Given this list of marker genes PTH1R, ISCU, EPS15, MMD, SSTR3, FABP6, LACTB, BDKRB2, EEF1AKMT1, UPB1, SUCO, NID1, CD72, SPTLC1, BHLHE23, ID4, TBL1X, CXCL10, FAM89B, TCEAL9, NUDT9, HVCN1, IGF2R, CUX2, RILPL1, TNFAIP8L1, CSRP1, STX1A, CPA3, TSHR, CD274, RTBDN, EPAS1, SARDH, CLDN23 (claudin 23), OSMR, COL8A1, NEK7, TGDS, MCCC2, PRDM5, UNC50, AKNA, MAPRE2, ST8SIA1, EMP3, CD84, ADAM10, WNT1, HOXB7, CLCF1, LTF, FBXL3, APOB, COX6C, TNFSF11 (NCBI Gene Id 8600), CKB, TPGS2, PLEKHA2, YEATS4, SRFBP1, FASLG, MAL, UCN2, SELENOV, PIP4K2A, TNFRSF1B, SYNJ2, SRPX2, TTC3, FABP9, LAD1, B3GNT2, DNAJC15 (DnaJ heat shock protein family (Hsp40) member C15), ADCY4, NRK, KRT7, SIRT2, MSRA, RASGRP4 (NCBI Gene Id 115727), SLC17A2, TRAPPC1, GLIPR1 (GLI pathogenesis related 1), SCNN1A, G6PC1, FAM184B, CCL20, ITM2A, IKBKB, KRTAP20-2, DNAJA3, GRIA4, CTSV, EFNA5, ECI1, RAB11B, HLA-G, SPINT2 (serine peptidase inhibitor, Kunitz type 2), HMGN5, PPP3CA, RBX1, BEX3, RRAS2, ACAA2, SESN1, GPR153, MBP, CD96, CCDC86, DUSP6, PUM3, TMEM258, EDARADD, PDC, ADAM19, NKX2-8, TRIB3, CD3G, CADM1 (cell adhesion molecule 1), TUBB2A, SH3BP5, VPS13C, TMCO6, CNTN6, LONP2, DENR, TNNT2, DPY30, OMD, CA2, TIMP2, GTF2IRD1, MRPS33, RTL6, PDLIM4, ARR3, GOLM1, TTC7B, ANP32A, HNRNPLL, PAG1, FYCO1, EPB41L2, CCDC102A, EMC9, RHOV, XCL1, CNIH4, EVI2A, MPC2, REEP3, SERPINC1, CARMIL1, MAPRE1, LMOD2, TUFT1, AREG, CAST, NKD2, PHLDA1, MBOAT7, STAG2, ANTXR1, FCGR2A, PDCL3, TBL1XR1, TMEM38B, SH2D1A, C8orf76, AKR1B1, PHLDB1, RPS6KA2, PIGP, IRF6, TBXAS1, H2AC25 (NCBI Gene Id 92815), FOXB1 (NCBI Gene Id 27023), PDE7A, SH3KBP1, UFSP2, ITGA6, TNFRSF17, GJB6, CST9L, ENPEP, SSBP3, OXLD1, IMP4, VAT1, RAB11A, EVX2, GM2A, TMEM243, PECR, SIT1, MYLIP, RENBP, INTS6L, HAGH, here is a description of the gene set: Regulation of lineage potential and transcriptional priming by Ikaros. New insight is provided into a bivalent regulation of lineage priming in the HSC and its lympho-myeloid restricted progeny the LMPP by the lymphoid lineage-determining factor Ikaros Whereas Ikaros is responsible for the activation of a cascade of lymphoid expression programs and for the establishment of lymphoid potential from the HSC to the LMPP it is also responsible for the repression of stem cell and erythroid genetic programs that are incompatible with further lineage restrictions emanating from the LMPP studied in species Homo sapiens Genes down-regulated in IKZF1 knockout: hematopoietic stem cells versus megakaryo-erythrocyte progenitors. from publication Ng SY, Yoshida T, Zhang J, Georgopoulos K (PMID 19345118) Human Gene Set: GSE15330_HSC_VS_MEGAKARYOCYTE_ERYTHROID_PROGENITOR_IKAROS_KO_DN